Given this list of marker genes CFD, PEA15, ARRDC3, GLRX, EIF4EBP1, LAMP2, POLR2H, ARG2, ST13, RGS2, LAPTM4A, LAMTOR4, ATP6V1D, ERRFI1, PLIN2, EIF1B (NCBI Gene Id 10289), GADD45A, IFI44L, SH3BP5, RNF114, SELENOK, IFI27L2, SERPINE1, MCHR1, LGALS3, UPP1, CIR1, IKBIP, CSTA (NCBI Gene Id 378889), NFE2L2, PMP22, PIP4P2, CDK4, MRPS6, UBE2L6 (NCBI Gene Id 9246), ATP6V0E1, ERO1A, SELENOM, SYF2, NTAN1, NDUFS4 (NCBI Gene Id 4724), VIM, AKAP12, SNX9, CNIH4, INSIG1, DRAP1 (NCBI Gene Id 119810), LAMTOR5 (late endosomal/lysosomal adaptor, MAPK and MTOR activator 5), LMAN1, SQSTM1, DYNLL1, SNX6, SDCBP, ANG, ZFP36L1, HNMT, ATP6V1G1, SAP18, CMIP, CIB1, RAC2, ARPC3, RPF2, CA12, PLAUR, DNAJC8, ENY2, DARS1, ZNHIT1, RPL22L1, EIF1, HEY2, ZNF395, H3-3B, TPT1, ATP6V1F, BAX, TMEM176B, TNFRSF14, AKR1C3, RPL36AL, NOL7, BRI3, AK4, RSL1D1, DDX41, ESD, SLC38A5, HLA-DPB1, CCDC59 (NCBI Gene Id 29080), PSMB9, SLC3A2, PLEKHA5, IFI44, HMOX1, LY96, SMIM26, FAM13A, FTH1, PPP1R14B, FAM210A, COPS8, VAT1, EVI2A, RGS3, CCDC85B, SNHG12, SPHK1 (sphingosine kinase 1), CEBPZ, CTSD, MSANTD3, TMEM50A, EMP3, IGFBP5, DPY30, ASAH1, SLC2A3, PPFIBP1, RAB32, TIMP1, PLTP, MRPL54, SNX2, CD68, AP2S1, OPTN, COA6, IFI16, TGFBI, RPS27L, FAM174C, GSTO1, HMGA1, A1BG, LIMS1, HEBP1, TMEM205, DHRS7 (dehydrogenase/reductase 7), WTAP, ODAD3, POMP, LRRFIP1, PRR13, ATP1B1, TRMT112 (NCBI Gene Id 51504), APOE, CYSTM1, VDAC2, THEMIS2, LY6E, UBE2B (NCBI Gene Id 7320), SGCB (NCBI Gene Id 6443), ICAM1, NEU1, SLC2A1, NCOA7, TUBA4A, LINC01436, BCAS2, SP100, HEXB, ANKRD37, CTSL, HSP90B1, SMS, RNASE4, C19orf53, COX5B, BNIP3L, TNFAIP6, NENF, TXNIP, SRGN, BTG1, SMIM3, INSIG2, APOD, MGAT1, SMIM29, TBCA, DAD1, RALA, PSMB8, FTL (ferritin light chain), here is a description of the gene set: from publication Su Z, Ho JWK, Yau RCH, Lam YL, Shek TWH, Yeung MCF, Chen H, Oreffo ROC, Cheah KSE, Cheung KSC (PMID 38267611) The transformation of benign lesions to malignant tumours is a crucial aspect of understanding chondrosarcomas, which are malignant cartilage tumours that could develop from benign chondroid lesions. However, the process of malignant transformation for chondroid lesions remains poorly understood, and no reliable markers are available to aid clinical decision-making. To address this issue, we conducted a study analysing 11 primary cartilage tumours and controls using single-cell RNA sequencing. By creating a single-cell atlas, we were able to identify the role of endoplasmic reticulum (ER) stress in the malignant transformation of conventional central chondrosarcomas (CCCS). Our research revealed that lower levels of ER stress promote chondrosarcoma growth in a patient-derived xenograft mouse model, while intensive ER stress reduces primary chondrosarcoma cell viability. Furthermore, we discovered that the NF-?B pathway alleviates ER stress-induced apoptosis during chondrosarcoma progression. Our single-cell signatures and large public data support the use of key ER stress regulators, such as DNA Damage Inducible Transcript 3 (DDIT3; also known as CHOP), as malignant markers for overall patient survival. Ultimately, our study highlights the significant role that ER stress plays in the malignant transformation of cartilaginous tumours and provides a valuable resource for future diagnostic markers and therapeutic strategies. species: Homo sapiens Human Gene Set: SU_HO_CONV_CENT_CHONDROSARCOMA_STROMAL_C2_GRANULATING_CANCER_ASSOCIATED_FIBROBLAST Characterized by granulocyte activation, with markers such as CD68, HLA-DPB1, and CFD.